Given this list of marker genes ZBTB11, ZFP36, RNF2, RBM25, KLF6, ZKSCAN1, SNIP1, MTA3, ATF6, PHF21A, ZNF197, NFIX, CHD4, ZNF341, GTF2I, ERF, ATF2, TRIM24, E2F6 (NCBI Gene Id 1876), NR2C2, USF2, CREB3L1, CREB3, SMAD4, TCF12, CXXC5, MAZ, CBFA2T2, TBP, USF1, HMG20A, FOS (NCBI Gene Id 2353), ID3, ZNF184, CUX1, ZBTB12, SIX5 (SIX homeobox 5), IKZF1, NCOR1, LARP7, SOX6, ARID1B, THAP1, ARID4B, ESRRA, ZNF24, ELK3, KLF16, ZFX, ZNF548, DACH1, AGO1, ZBTB17, NR4A1, SIN3A, SP2, KLF13, SP1, TFCP2, RAD21, CBFA2T3, NONO, NSD2, CTBP1, ZKSCAN8, ZNF639, STAT5A, ATF3, HDAC8, SREBF1, NFE2, ZNF143, KDM5B, ZNF512, NFIC, ZBTB5, ZNF316, CHD1, TRIM25, JUN, PCBP1, MTA2, NR2F1, TARDBP, TRIM28, RBFOX2, ZNF436, SPI1, ZNF444, ETV6, RCOR1 (REST corepressor 1), ZNF764, E4F1, GABPA, BHLHE40, ZNF589, RLF, CREM, THAP12, ZNF281, SAP30, PBX2, CTCFL, ASH1L, NR2C1, SKIL, ZNF740, ZNF121, RB1, BCLAF1, SMAD5, GATA2, DDX20, HNRNPLL, CC2D1A, GABPB1, SIN3B, TCF7, CDC5L, GATAD2B, IRF2, POLR2A, BCOR, AFF4, TAF1, ELF1, PRPF4, ZBTB7A, ZNF783, TCF3, MXI1, STAT6, FOXK2, MIER1, STAG1, GTF3C2, ZNF644, GTF2E2, FOXO4, RBM4, ETV1, TEAD4, SMAD1, TBL1XR1 (NCBI Gene Id 81612), ZFP64, GATA1, ZSCAN22, FOXJ2, HNRNPK, ZSCAN29, EGR3, GATAD2A, HDGF, MYNN, NRF1, SMARCE1, REST, YY1, SUPT5H, FOXK1, ZBED1, ZNF7, E2F1, MAFK, HDAC2, ZBTB33, L3MBTL2, ZNF584, ELF4, DMBX1, ZNF175, POLR2G, E2F5, DEAF1, SAFB, HNRNPL, CCNT2, ZEB2, BRD4, DPF2, HLTF, FOXP1, ZNF83, MTA1, ZNF467, ZNF692, NKRF (NCBI Gene Id 55922), U2AF1, FUS, EGR1, RFX1, VEZF1, CBX3, MYBL2, NBN, FOXA3, KDM4B (NCBI Gene Id 23030), ZMYM3, HMGXB4, KDM1A, JUNB, HCFC1, SRSF3, ARID3A, ZNF511, PHF20, KLF1, MBD2, ATF4, SMARCC2, RBM22, SRF, HBP1, MYC, RUNX1, NR2F2, MLLT1, SP4, ATF1, UBTF, CBX1, GTF2F1, MEIS2, E2F8, CEBPB, AFF1, ZNF431, CEBPZ, LEF1 (lymphoid enhancer binding factor 1), HMBOX1, NEUROD1, NFRKB, NR2F6, ZNF395, PML (PML nuclear body scaffold), MXD1, HES1, ZNF202, ZNF12, ZNF189, ZNF766, RBBP5, XRCC5, ATF7, HMGN3, MAX, ZIC2, KAT7 (NCBI Gene Id 63437), ZNF583 (NCBI Gene Id 147949), PTBP1, SMARCA5, FIP1L1, KLF15, ETS1, JUND, ZBTB2, ZNF318, FOXM1, CTCF, NFATC3, TFAP4 (transcription factor AP-4), POLR2B, ZNF35, PHF8 (NCBI Gene Id 57793), ZNF479, EP300, ZNF282, NCOA1, HDAC1, PKNOX1, ZNF263, ZNF317, EP400, CEBPG, SMARCA4, MNT, ZNF384, ZC3H8, ZNF334, RBM34, ZFP91, E2F4, MITF, ARNT, EGR2, BACH1, RAD51, CHD2, ZNF148, MEF2A, GMEB1, ETV5, LCOR, RFX5, ZNF3, CREB1, PHB2, RELA, NFYB, PRDM10, MEF2D, TOE1, GLIS1, NFYA, ZBTB9, ZBTB40, TEAD1, TAL1, SUZ12, TFDP1, ZNF592, BRD9, FOSL1, SMC3, here is a description of the gene set: Transcription factors and DNA binding proteins enriched at promoters of genes whose expression fluctuates during the cell cycle (pVal < 0.05) and peak in G2/M in K562 species: Homo sapiens Transcription regulation during the cell cycle is crucial for ensuring genes are expressed at the right time and in the correct amounts, coordinating key processes like DNA replication, mitosis, and cell division. In our study, Human Gene Set: PULVER_FOREY_CELLCYCLE_ENRICHED_TFS_G2_M